Given this list of marker genes Slc3a2, Eif3b, Ppa1, Calr, Tmed2, Tubb4b, Ppp1r14b, F2r, Ost4, Itgb7, Nt5c, Eif5a, Tmem176b, Arhgdia, Ppib (peptidylprolyl isomerase B), Rabac1, Lgals1, Lsm4, Ifngr1, Cxcr6, Hspa5, Pdlim2, Sdf2l1, Capg, Manf, Nme1, Cysltr1, Socs1, Rbm3, Eno1, Tpst2, Rexo2, Pnp, Trac, Fbl, Mdfic, here is a description of the gene set: Genes positively differentially expressed in cell type: γδ T cell upon treatment with cytokine: TSLP in mouse lymph nodes in vivo. Cytokines mediate cell-cell communication in the immune system and represent important therapeutic targets. A myriad of studies have highlighted their central role in immune function, yet we lack a global view of the cellular responses of each immune cell type to each cytokine. To address this gap, the authors created the Immune Dictionary, a compendium of single-cell transcriptomic profiles of more than 17 immune cell types in response to each of 86 cytokines (>1,400 cytokine-cell type combinations) in mouse lymph nodes in vivo. A cytokine-centric view of the dictionary revealed that most cytokines induce highly cell-type-specific responses. For example, the inflammatory cytokine interleukin-1β induces distinct gene programmes in almost every cell type. A cell-type-centric view of the dictionary identified more than 66 cytokine-driven cellular polarization states across immune cell types, including previously uncharacterized states such as an interleukin-18-induced polyfunctional natural killer cell state. from publication Cui A, Huang T, Li S, Ma A, Pérez JL, Sander C, Keskin DB, Wu CJ, Fraenkel E, Hacohen N (PMID 38057668) studied in species Mus musculus Mouse Gene Set: CUI_T_CELL_GD_TSLP_RESPONSE_UP